The following is a description of a gene set: Human Gene Set: GOBP_THROMBOPOIETIN_MEDIATED_SIGNALING_PATHWAY studied in species Homo sapiens The series of molecular signals initiated by thrombopoietin binding to its receptor on the surface of a target cell, and ending with the regulation of a downstream cellular process, e.g. transcription., and this is the list of marker genes: STAT5A, THPO, JAK2 (Janus kinase 2), MPL, SH2B3, CIB1, RBM15